The following is a description of a gene set: Human Gene Set: PULVER_FOREY_PERTURB_ACCUMULATION_G1_S Transcription regulation during the cell cycle is crucial for ensuring genes are expressed at the right time and in the correct amounts, coordinating key processes like DNA replication, mitosis, and cell division. In our study, Genes whose depletion leads to accumulation of cells in G1/S (pVal < 0.05) in K562 Repogle et al., 2022 reanalyzed with Velocycle from Lederer et al., 2024 studied in species Homo sapiens, and this is the list of marker genes: TBXA2R, TBX4, AKAP13, ZNF267, DGUOK, POLL, DNAJC9, GMDS, GTPBP6, DAPK1, XK, TJP1, SLC12A9, FAH, FLNC, HSD17B11, DLX5, NCOA7, DIS3L2, OR2T5, GCC2, NKIRAS2, PSME1, SH3GLB2, HSD17B8, DCAF5, CTSL, SUN1, TGFBR3, CXorf38, RETREG2, KIAA1191, AUNIP, LAMTOR5, JARID2, KLF10, LMNA, EMD, POFUT1, DGKQ, MRPL37 (mitochondrial ribosomal protein L37), PARS2, CRY2, RNF138, EIF2AK3, UQCC5, UBE2D3, BUB1, GYPE, GNB2, ESYT2, C11orf24 (chromosome 11 open reading frame 24), SLC39A11, TMEM19, GAPVD1, GOLPH3, MEST, AMBRA1, EIF4EBP1, TRUB2, MAPKAPK5, CSAG1 (chondrosarcoma associated gene 1), PDE7A, SSX1, NUDT22, SIL1, SULT1A3 (sulfotransferase family 1A member 3), ATG16L1, TMED5, ATP9B, GDPD5, WDHD1, PDXK, ARL5B, COPZ1, CTSA, DUSP13B, FOXN4, GPATCH2L, RBCK1, TMEM68, ZNF732, METTL5 (NCBI Gene Id 29081), P4HA2, PNMA1, CNN2, MAPK8IP3, TRRAP, KBTBD6, FASTKD3, DAZAP1, COMMD5, LMO4, DIABLO, NFYB, PSME3IP1, RFNG, RIOX1 (ribosomal oxygenase 1), AP1M1, NDUFS3, DCLRE1A, OARD1 (NCBI Gene Id 221443), PPIL3, NDUFC2, DHX34, LRPAP1, LMAN2L, CHPT1, ITPRIP, LPGAT1, BHLHA15, TCF15, E2F2, ATF3, KDM4A, PGAP2, EMC9, ARHGEF39, BTN3A2, STK38, TEF, SOCS2, CETN3, PAAF1, DZIP1, JAG2, ZNF646, BRD3, ARHGAP22, COMMD7, DPM3, GPR180, TRAF2, DRG2, ECE2, NDUFB3, AKR1C1, GLRX3, IL17RC, HNRNPA3, BARD1, BLOC1S1, PI4KA, HOMER1, TRAK1, PFKM, ZFP36L1, FZR1, ERF, RNF19A, ZNF630, LHX3, KTN1, SMYD5 (NCBI Gene Id 10322), H2AC18, MRPS16, ANHX, SSBP2, BCKDK, DECR1, JAGN1, STXBP1, MTCL2, EGR1, PTP4A1, ERP29, NGRN, MBNL1, TBL1X, CR1L, COQ10A, ARL15, CUTA, GALK1, CBFA2T3, TCF24 (NCBI Gene Id 641383), TK1, MAFK (NCBI Gene Id 7975), H2AX, DGKE, GRPEL1, ARHGAP45, SSR1, LRRFIP2, BCL11A, NIPSNAP2, VKORC1L1, AGPAT5, THAP12 (NCBI Gene Id 9137), MON1B, RHBDD1, CHD7, ETNK2, CHCHD3, ANKRD11, PBX3, MIB2, DENND4C, MEF2C, N6AMT1, RHAG, HOXB3, UBE2D1, INHBE, RNF115, CALM2 (calmodulin 2), RFX4, TFAM, CNOT8, TAF13, MFSD3, NDUFA3, H3-3A, AXL, CHTOP, MIER2 (NCBI Gene Id 54531), TULP1, ANKS1A, SELPLG, RMDN3, TSPAN13, HNRNPU, CENPH, BCL7A, ANO6, CRTC3, GLI1, ZNF622, HSBP1, LRIG2, KIF2A, TMEM39B, PHOSPHO2, CKS2, POLR3G, ADISSP, SIAH2, TBC1D22A, LRRC8B, ANAPC7, BET1L, ANKRD13B, CLCC1, NKAP, MANBA, UPF2, VAC14, TOR1AIP2, DOCK6, SLC2A13, COPS9, ASF1B, CSNK1G3, POGK, PEX10, DHRS7B, ZNF90, NEU3, MRC2, CISH, PHOX2A, ZNF430, PAGE5, HSDL2, RAB7A, DEF6, TGOLN2, DFFB, TIMM29, MCAM (melanoma cell adhesion molecule), ALDH18A1, H3C7, SMARCA4, CREBL2, DSG2, DOCK9, ZNF850, TCF12, POR, BZW1, CCNT2, PHACTR4, CAPN10, ARAF, PKLR, FADD, MLEC, FBXO8, IFT88, RASA2, COMMD6, TNKS2, OTUD7B, E4F1, RNF11, TMEM41A (NCBI Gene Id 90407), DNMT1, AP4B1 (adaptor related protein complex 4 subunit beta 1), SNX1, NKX6-2, HM13, UNK, GLOD4, NEDD4L, F11R, QTRT2, FBXO45 (F-box protein 45), PRPSAP1, SLC16A5, PCNP, SOD1, CDK5RAP3, SNTA1, ARHGDIA, EMX1, PCOLCE2, TFDP1, DOK2, BARX1, PMVK, SMARCB1, SLC30A9, CEBPE, TIGD6, APPBP2, GLT8D1, ZNF846, APOM, ZNF329 (zinc finger protein 329), PHACTR2, SZT2, FBXL8, STOML1, CDK2, CSNK1G2, ZNF114, CCDC32, BLCAP, SZRD1, HIVEP2, EBF1, KLF15, FNDC3A, SLC35C2, CCSER2, RPS6KL1, MRPS7, ECHDC1, RHOH, NCLN, ZNF577, FAM110A, SCAMP2, CANX, SDF2, PPP1R3E, INPP5K, ERN1, TRIM5, NCOA1 (nuclear receptor coactivator 1), LRP10, NSUN6, SP140, GJA3, SLC35B1, C11orf71, TAB2, PAXX, SHARPIN, PRDX2, CCM2, AARSD1, YEATS4, PHPT1, CTSV, DCAF16, PHF20, LHX8, RILPL2, TMBIM6, ZNF491, CAPG (NCBI Gene Id 822), NAA11, ZNF471, EGLN2, ZNF221, HIKESHI, MAGEA9B, SMARCC1, RALGAPB (NCBI Gene Id 57148), RPRD1B, PPP6C, RILP, POM121, GABRG3, PSEN2, MCFD2, DVL1, SPTB, SELENOI, LANCL2, STAU2, IER5, GRK2, TFDP3, GFM1, RAI1, TRNAU1AP, AGGF1, VAPA, NEBL (nebulette), ABHD11, RAP1GAP, DDI2, BCL6B, ODR4, WDFY1, ZFYVE16, NEK9, MIDN, ZNF789, GSTZ1, CCDC107, THEM6, METTL9 (methyltransferase 9, His-X-His N1(pi)-histidine), GRAP2, FUS, NEU1, RBBP7, CCHCR1, RANBP9, PKIG, POLD4, DYNC2I1, NF2, DGLUCY, ZNF607, PRR5, MAP7D1, PHYKPL, RNF220, ICAM5, CT45A5, SPTSSA, PSME2, PPCDC, FAM124B, MRPL10, BCKDHA, ARID3C (NCBI Gene Id 399524), MRFAP1L1, CDC42EP4, STAT1 (signal transducer and activator of transcription 1), RNF8 (NCBI Gene Id 9025), RBX1, SEC11A, CAMKMT, NR1D2, LCP1, MLXIPL, CORO1C, CRY1, PARN, CDK17, OSBPL11, CPXCR1, SHMT1, RSBN1, GYG1, RETSAT, HOXD3, PINK1, FRG1, ADIPOR2, KMT2E, AK2, ARSK, PAFAH1B2, CCDC117, KRTAP4-2, RAB10, DERL1, PATZ1, CAB39, CPNE2, MEA1, HNRNPF, ELK3, EBAG9, DIPK2A, POLA1, GALC, STARD8, KRT18 (NCBI Gene Id 3875), MRPL36, LIN28A, DESI1, ZNF439, NTAN1, OSGIN2, RSKR, TENT4A, ADD1, CTNNAL1, FIGLA (NCBI Gene Id 344018), HOXD13, RCE1, NADK2, SIVA1, RTL8C, TM9SF3, GCLC, HEMK1, UQCC2, MCUB, SHQ1, ISL2, TALDO1, GALNT10, ATG2B, CDC25A, ARF6, FKBP5, BECN1, SAC3D1, RPS6KA1, TCF4, CPPED1, GPATCH3, TDRKH, EN2, NPB, PDP2, STAG2, DDX5, RGS16, ALDH9A1, SOX14, CORO7, SETD3, TVP23B, PPP1R15B, ZNF543